The following is a description of a gene set: Reactome Pathway: Phosphorylation of Emi1 species: Homo sapiens part of: Regulation of APC/C activators between G1/S and early anaphase The phosphorylation of Emi1, which is required for its degradation in mitosis, appears to involve both Plk1 and Cdk1., and this is the list of marker genes: FBXO5, FZR1, CDK1, CDC20, PLK1, CCNB1